Given this list of marker genes MYL3, TBX1, SFMBT1, SMTNL1, MEGF10, MYORG, MYOM2, EOMES, MKX, PAX7, SIX4, CAPN3, ARID5B, TIFAB, SMTN, FRG1 (NCBI Gene Id 2483), MYMK, SELENON, DLL1, EMD, RYR2, BORCS8-MEF2B, MYMX, ZFPM1, TGFB1, VRK3, TCF15, MTPN, SIRT1, CENPF (NCBI Gene Id 51468), FZD2, KAT8, HOXD9, USP19, MYH3, MYF5, EID2B, ASS1, HLF, MYBPC3, UNC45B, AKIRIN1 (NCBI Gene Id 79647), CXCL10, SGCD, CITED2, FOXK1, FOS, RBPJ, NPHS1, BCL2, XBP1, FHL1, BMP4, SGCG, TCF23, SIRT2, KEL, MYL6, CAV2, VAX1, DAG1, ITGA7, MTM1, BMPR1A, KLHL40, COPRS, BTG2, CAV1, MEF2C, MIR1-1, ANKRD2 (NCBI Gene Id 26287), MEOX2, FGF3, MYOZ2, PRR14, SAP30, NRG1, CHRNA1 (cholinergic receptor nicotinic alpha 1 subunit), DDX5, ASB2, DSP, FHL3, YBX3, IGF2, EGR2, MUSTN1, SPG11, CNTF, VAMP5, POPDC2, ERO1A, SMAD7, BMP2, MCUB, NAGLU, PITX1, BASP1, COL3A1, CD164, MYLK2, FOXH1, FKTN, DCANP1, CACNA1H, RHOA, MYH7, PKP2, NR1D2, DNER, TTN, NOTCH1, PPP3CB, CCNT2, ZFPM2, NKX2-5, MYF6, PROX1, RB1, ANKRD1, FGF8, FBXO22, FOXC1, TGFBR3, OR10J5, CHKB (choline kinase beta), TAGLN, RYR1, LARGE1, LAMA5, POPDC3, SCN11A, ACTN3, HIVEP3, SGCA, MEF2A, USP2, PPIF, SGCE, HBEGF, GPCPD1, H1-5, CFL2, VANGL2, PPP3CA, RBM24, MYL11, STRA6, KMT5B, BMP10, ISL1, TWIST1, ITGA11, CHRND, SOX15, LRP2, MYC, PRKAA1, CREB1, CSRP3, CACNA1S, MAPK12, MRTFB, EPHB1, TCAP, NF1, CNTNAP1, P2RX2, MSX1, HMG20B, VPS54, SIX1, HEY2, SRPK3, SERP1, EEF2, EFEMP2, LMNA, COL6A3, UQCC2, CDON, EGLN1, TNNI1, NACA, PHOX2B, EGR1, MEF2B, HDGFL2, TLL2, HDAC9, ASNSD1, UNC45A, WT1, BMAL1, PAX3, ANHX, LEMD2, CDK5, PAX5, VPS13B, ID3, HLX, DMD, KY, SKIL, WNT10B, MAPK14, FOXC2, SMO, FOXN2, HSD17B1, GPC1, VGLL2, TCF21, FKBP1A, TBX20, ERBB3, ADARB1, FZD1, COL19A1, TNNT2, GSC, KRAS, MSTN, SOX8, NR4A1, STAC3, UTRN, DPF3, SVIL, MEF2D, GPX1, SKI, EVC, PTCD2, CHD7, CHD2, ZBTB18, HOMER1, FOXL2, BARX2, CNTFR, HEYL, LUC7L, SMYD1, MIR145, TMEM182, ZNF609, EP300, EGR3 (early growth response 3), ZBTB42, RIPOR2, BCL9, HAND1, NR2F2, RCAN1 (NCBI Gene Id 1827), LEF1, MYLK, SMAD4, EID2, KLF5, ACTA1, WNT3A, TRIM72, SGCB (NCBI Gene Id 6443), B4GALNT2, LOX, METTL21C, MYL6B, MYH6, NLN, SHH (sonic hedgehog signaling molecule), MYL2, COL6A1, CAVIN4, ITGB1BP2 (NCBI Gene Id 26548), MYH14, ZNF689, FOXP2, LBX1, TCF12, IGSF8, DES, LIF, ZFHX3, ETV1, ENG, UBE4B, BVES, HOXD10, LAMA2, GMPPA, SMAD3, IGF1, CASQ1, FOXO4, NEGR1, GTF3C5, ATF3, POU4F1, ITGB1, FGFRL1, S100B, XIRP2, SOX11, FXR1, MIR195 (microRNA 195), DLL4, JPH1, COL11A1, MYOG, CFLAR, MIR143, CRYAB, PITX2, FLNB, MAFF, MYOD1, FKRP, ELN (NCBI Gene Id 2006), WNT2, NUPR1, MED20, BTBD1 (NCBI Gene Id 55029), MED1, CTF1, ABCC9, XK, NEB, S1PR1, MSC, TGFBR1, EDNRA, PAXBP1, TEAD4, MYH15, KLHL41, DDX17, ACTC1, TNNC1, DISP1, SHOX2, LMOD3, SOX6, TGFB2, CTNNB1, MYOCD, ALX4, NEUROG1, ADGRB1, FGFR2, NEURL1, TPM1, BIN3, CYP26B1, RPL3L, BCL9L, SPEG, DMRTA2, PLEC, HEG1, FLOT1, POU6F1, MYOM1, TNNI3, COPS2, MYOZ1 (NCBI Gene Id 58529), CAV3 (caveolin 3), ANKRD33, NOG, JPH2, SCX, CHODL, here is a description of the gene set: studied in species Homo sapiens Human Gene Set: GOBP_MUSCLE_ORGAN_DEVELOPMENT The process whose specific outcome is the progression of the muscle over time, from its formation to the mature structure. The muscle is an organ consisting of a tissue made up of various elongated cells that are specialized to contract and thus to produce movement and mechanical work.